The following is a description of a gene set: Human Gene Set: MEISSNER_NPC_HCP_WITH_H3K27ME3 studied in species Mus musculus from publication Meissner A, Mikkelsen TS, Gu H, Wernig M, Hanna J, Sivachenko A, Zhang X, Bernstein BE, Nusbaum C, Jaffe DB, Gnirke A, Jaenisch R, Lander ES (PMID 18600261) DNA methylation is essential for normal development and has been implicated in many pathologies including cancer. Our knowledge about the genome-wide distribution of DNA methylation, how it changes during cellular differentiation and how it relates to histone methylation and other chromatin modifications in mammals remains limited. Here we report the generation and analysis of genome-scale DNA methylation profiles at nucleotide resolution in mammalian cells. Using high-throughput reduced representation bisulphite sequencing and single-molecule-based sequencing, we generated DNA methylation maps covering most CpG islands, and a representative sampling of conserved non-coding elements, transposons and other genomic features, for mouse embryonic stem cells, embryonic-stem-cell-derived and primary neural cells, and eight other primary tissues. Several key findings emerge from the data. First, DNA methylation patterns are better correlated with histone methylation patterns than with the underlying genome sequence context. Second, methylation of CpGs are dynamic epigenetic marks that undergo extensive changes during cellular differentiation, particularly in regulatory regions outside of core promoters. Third, analysis of embryonic-stem-cell-derived and primary cells reveals that 'weak' CpG islands associated with a specific set of developmentally regulated genes undergo aberrant hypermethylation during extended proliferation in vitro, in a pattern reminiscent of that reported in some primary tumours. More generally, the results establish reduced representation bisulphite sequencing as a powerful technology for epigenetic profiling of cell populations relevant to developmental biology, cancer and regenerative medicine. Genes with high-CpG-density promoters (HCP) bearing the H3K27 tri-methylation (H3K27me3) mark in neural precursor cells (NPC)., and this is the list of marker genes: NELL1 (NCBI Gene Id 4745), KCNK15, GFI1, ATP2B2, KCNQ1, HOXD12, CRB3, COL15A1, HOXC12, GSX2, HOXB9, WNT10A, HOXA10, CCKBR, HOXC13, DRD2, PPM1N, HOXC11, FEZF2, PRKCZ, MIXL1, NKX2-5, GPR139, GPR37, PDX1, OTP, CYP2S1, PAX7, NEUROG3, LHX5, HNF1B, SIX6, IGF2BP1, POU2F3, CA10, TMEM181, PYY, ATP12A, HOXC8, SFRP5, SLC7A14, HTR1A, HOXB5, GRM7, HOXD9, HOXB6, ALX1, AJM1, HOXD10, HOXB7, VSTM2L, B4GALNT2, RIPK4, HES2, TCFL5, CARTPT (CART prepropeptide), FSTL4, ST8SIA3, DMRT1, CBLN2, TFAP2C, FOXN4 (NCBI Gene Id 121643), C1QTNF4, TMEM114, SIGIRR, BHLHE23, GATA5, HCK, ALX3, JHY, PRDM13, SCNN1G, HOXA11, HOXB4, MESP1 (mesoderm posterior bHLH transcription factor 1), CDX2, OTOP1 (otopetrin 1), DIO3, FOXL1